Given this list of marker genes ADCY9, ADCY1, TG, ADCY5, CREB3L3, ATF2, ADCY6, CREB1, TSHR, ATF4, CREB3L1, GNAS, TSHB, CREB5, TTF1, CREB3L4, PRKACA, ADCY3, CREB3L2, CREB3, PRKACG, ADCY7, PRKACB, TTF2, ADCY2 (adenylate cyclase 2), ADCY4, ADCY8, ATF6B, PAX8, here is a description of the gene set: TSH-TG signaling pathway. Pathway ID: N00782. Pathway type: Reference. Pathway class: nt06322 TRH-TSH-TH signaling. studied in species Homo sapiens Human Gene Set: KEGG_MEDICUS_REFERENCE_TSH_TG_SIGNALING_PATHWAY Pathway Definition from KEGG: TSHB -> TSHR -> GNAS -> ADCY -> cAMP -> PKA -> (TTF1,TTF2,PAX8,CREB) => TG